The following is a description of a gene set: Mouse Gene Set: GOCC_OLIGOSACCHARYLTRANSFERASE_COMPLEX studied in species Mus musculus A protein complex that is found in the endoplasmic reticulum membrane of eukaryotes and transfers lipid-linked oligosaccharide precursor to asparagine residues on nascent proteins. The complex includes at least eight non-identical subunits. Different forms of the complex containing distinct subunits have been detected in mammals., and this is the list of marker genes: Ddost, Rpn2, Tmem258, Dad1 (NCBI Gene Id 13135), Ostc, Tusc3, Mlec, Ost4, Krtcap2, Rpn1, Stt3b, Magt1, Trex1, Stt3a